Given this list of marker genes PSEN1, TTN, RRM2B, ACADVL, PPCS, CAP2, TNNC1, COQ4, DSG2, LMNA, FKTN, SCN5A, MYBPC3 (NCBI Gene Id 4607), MYH6, RRAGC, POLG2, CORIN, VEZF1, RPL3L, MYOZ2, SDHA, VCL, LAMA4, DYSF, MYZAP, TOP3A, NEXN, RAF1 (NCBI Gene Id 5894), SLC25A4, ABCC6, POLG, NPPA, AARS2, TTR, TNNI3, MYH7, COA6, SGCD, GATAD1, MYL3, RRAGD, TWNK, TNNT2, B2M, GNPTAB, LMOD2, DES, BAG5, GTPBP3, LAMP2, PSEN2, MRPL39, GET3, LAMA2, FLII, CSRP3, CRYAB, FHOD3 (NCBI Gene Id 80247), KCNJ5, GJA5, KCNJ2, here is a description of the gene set: Any abnormality of the left ventricular ejection fraction (LVEF), which is the fraction of chamber volume ejected in systole (stroke volume) in relation to the volume of the blood in the ventricle at the end of diastole (end-diastolic volume). Stroke volume (SV) is calculated as the difference between end-diastolic volume (EDV) and end-systolic volume (ESV). LVEF is calculated as in percent. Human Gene Set: HP_ABNORMAL_LEFT_VENTRICULAR_EJECTION_FRACTION studied in species Homo sapiens Abnormal left ventricular ejection fraction